Given this list of marker genes Nanp, Gne, Cmas (NCBI Gene Id 12764), Nans, Slc35a1, here is a description of the gene set: The chemical reactions and pathways resulting in the formation of CMP-N-acetylneuraminate, a substance composed of 5-(acetylamino)-3,5-dideoxy-D-glycero-D-galacto-non-3-ulosonic acid in glycosidic linkage with cytidine monophosphate. Mouse Gene Set: GOBP_CMP_N_ACETYLNEURAMINATE_BIOSYNTHETIC_PROCESS species: Mus musculus